Given this list of marker genes MGAM2, SI, GAA, GANC, MGAM, here is a description of the gene set: Catalysis of the hydrolysis of terminal, non-reducing alpha-(1->4)-linked alpha-D-glucose residues with release of alpha-D-glucose. Human Gene Set: GOMF_ALPHA_1_4_GLUCOSIDASE_ACTIVITY studied in species Homo sapiens